The following is a description of a gene set: Cleft palate is a developmental defect of the palate resulting from a failure of fusion of the palatine processes and manifesting as a separation of the roof of the mouth (soft and hard palate). species: Homo sapiens Human Gene Set: HP_CLEFT_PALATE Cleft palate, and this is the list of marker genes: SLC35B2, SMARCB1, TRIP13, GDF3, RPS19, FANCF, ITGA8, DLK1, CPLX1, CHRNA1, DVL3, TMEM107, EIF4A3, HES7, PLCH1, RIPK4, GNAI3, NODAL, MECOM, MKKS, RAD51C, MAPRE2, PIGP, ORC6, GP1BB, PPP2R5D, EDN1, DISP1, NPHP1, MID1, GRHL3, FTO, CDH11 (NCBI Gene Id 1009), TRRAP (NCBI Gene Id 8295), ARHGAP29, POLR1D (RNA polymerase I and III subunit D), STIL, COL11A2, SUFU, PHF8, KCNN3 (potassium calcium-activated channel subfamily N member 3), MEGF10, FANCE, SOX3, RPS29, HDAC9, UBE2T, JUP, NDUFB11, ARNT2, FLRT3, SLC18A3, DPYSL5, SMOC1 (SPARC related modular calcium binding 1), PNKP (NCBI Gene Id 11284), PGM1, TBX2, SCN2A, SLC35D1, SON, COL9A3, POMK, BRAF, NXN, ZMPSTE24, KAT6B, GPC3, SLC25A19, SLC10A7, EARS2, MEOX1, RPS23, HAAO, FOXP2, SCN1B, COBLL1, POMT2, COL2A1, SEPTIN9, CHD7, MAP3K7, NAE1, AR, POMGNT2, HSPG2, TMEM67, STAT3, WDR26, HS6ST1, NELFA, EIF5A, GNRHR, STAG2, ESCO2, TRAPPC2, DLL3, INPP5E, DEAF1, FOXC2, COLEC11, FOXH1, CTBP1, MAP2K2, SMAD3, HS2ST1 (NCBI Gene Id 9653), TXNDC15, CEP152, MAPK1, ESS2, MESP2, TUBB, NSUN2, DLL1, RPL15, RBM10, ORC4, RIC1, ATR, TOPORS, DGCR8, GATA3, TCOF1, EDEM3, SCARF2, PITX1, TBR1, EIF2S3, ZPR1, ARCN1, SIX1, FKRP, GATA1, RPS17, GNB2, PAX3, PLAG1, CHRNG, SMCHD1, NDNF, MSX2, CHN1, TXNL4A, SOX10 (NCBI Gene Id 8223), C2CD3, B3GALT6, MSX1, NOTCH3, SUMO1, PDZD8, TWIST1, VAX1, SELENOI, RPL26, PGAP3, BMP4, SNRPN, PROP1, HIRA, MAMLD1, IGF2, DLG1, SCNM1, TMEM216, SOX9, TAPT1, COLEC10, TBX15, KIAA0753, SLX4, ACBD6, PTDSS1, MCTP2, NUP107, NFIX, JARID2, FKBP14, ATP6V1B2, RPL27, PTCH1, PIGN, POGZ, MASP1, KISS1, NFASC, PROK2, ATN1, PEX7, ANOS1, TCTN2, IGBP1, FANCB, PGAP2, CASK, SMS, BMPER, LMBRD1, RPGRIP1L, CHSY1, MT-CYB, FOXF1, H4C5, NSD2, LIG4, CEP120, MED25, TBX6, GNPAT, ERCC4, GLI3, CREBBP, EPG5, DEF6, AHDC1, BRIP1, RPS24, RPL5, CRPPA, WNT9B, CDT1, INTS1, MUSK, DYRK1A, MEIS2, FGF20, SCUBE3, GDF6, MAD2L2, CRKL, WBP11, FOXA2, TAF4, FAM50A, KLHL41, CARS1, SIX3, FANCL, RPL8, USP9X, GAD1, INPPL1, SPECC1L, FLNA, MYL11, RFWD3, OFD1, CCN2, CEP57, TFAP2A, TP63 (NCBI Gene Id 8860), POMT1, SHH, DONSON, B9D2, HNRNPK (NCBI Gene Id 3190), HCCS, PLXND1, SMC1A, MEG3, YAP1, PDGFRA, MYMK, GNAO1, ARID1A, WBP4, ECEL1, TCTN1, TGFBR1, GAS1, FAM149B1, HEATR3, RREB1, PDE6D, RPS10, SPRY4, LMX1B, SLC26A2 (solute carrier family 26 member 2), DLG5, TFE3, WNT3, BCOR (BCL6 corepressor), LRRC32, WASHC5, ZNF469, NIPBL, NR4A2, JMJD1C, B3GALNT2, PRR12, TGFB3, RXYLT1, FANCI, KDM6A, WNT5A, PUF60, MAFB, RNU4ATAC, RECQL4, NEDD4L, TMEM237, SEMA3A, DLX4, RAD51 (NCBI Gene Id 5888), RAB34, PRKAR1B, RAD21, POLR3A, KCNJ2, AHI1, EFTUD2, GLI2, DVL1, BUB1, SEMA3E, SEC23A, KIF15, UFD1, MED12, TACR3, HMGA2, GREB1L, SPINT2 (NCBI Gene Id 10653), FGD1, DLX5, TGFBR2, KIF21A, SIAH1, FBXO11, FKTN, RAPSN, DSP, RPS26, DGCR2, GMNN, ASCC3, PRDM5, DHCR7, SMO, SALL4, RUNX2, CRELD1, KIF7, ARHGEF38, BUB3, GPC4, ANKRD11, KAT5, UBB, BUB1B, TUBA1A, BRD4, ARVCF, ZEB2, PALB2, GMPPB, CHST3, RNU12, FGF17, LZTR1, GNB1 (NCBI Gene Id 87729), CC2D2A, SMARCD1, SLC25A22, CCDC32, CSPP1, HESX1, AMMECR1, PORCN, DUSP6, RPL35A, SLC2A10, RPL31 (ribosomal protein L31), NUAK2, LHX4, FEZF1, ADA2, RPS20, POLR1A, LETM1, PTPN11, RSPO2, CHRND, FRAS1, SF3B2, MYH3, RPL9, MAGEL2, POMGNT1, DMXL2, CDKL5, FGFR1, ALX3, FLVCR2, TCTN3, ATP6V1E1, ALX1, IPO8, CHST14 (NCBI Gene Id 89881), CCDC141, CYP26C1, FOXE1 (forkhead box E1), RPS27, TAC3, CENPF, ARID1B, FGFR2, OTX2, NEK1, RARB, ZIC2, WNT7A, PIGV, RPL35, CRIPTO, RET, RPS7, KISS1R, TAF6, FOXI3, ALX4, CDC6, DPH1, WDR11, PIGQ, ZFX, GRM7, RPS28, CDON, NONO, DOK7, NUP88, SMC3, MAF, FANCG, RPL18, PEX2, ORC1, CDC45, RIPPLY2, SNRPB, DSE, PEX5, B3GAT3, ARHGAP31, HYAL1, COL4A1, LARS2, WNT4, TMCO1, RB1, RBM8A, EYA1, NBN, FAM20C, ACTB, BPNT2 (NCBI Gene Id 54928), TMEM231, POLR1C, FANCD2, CHUK, GNRH1, SETD5, FANCC, B9D1, BRCA2, KRAS, PSAT1, B4GAT1, CDH1, LARGE1, KATNIP, KIAA0586, SMARCA4, GRIN1, SLC32A1, COL11A1, KMT2D (NCBI Gene Id 8085), GDF11, SH2B1, CTNND1, KDF1, HDAC8 (NCBI Gene Id 7492), NOTCH2, INTU, PIEZO2, FGF9, TBX4, STAC3, COL9A1, WDR35, PQBP1, FGFR3, COMT, TBX1, ACTG2, POLR1B, ZC4H2 (NCBI Gene Id 7493), SF3B4, CEP41, REV3L, EBP, POLR2A, RPL11, NEUROD2, NECTIN1, KANSL1, PLCB4, MYMX, LEMD3, EBF3 (EBF transcription factor 3), HOXD13, ACBD5, ARX (NCBI Gene Id 619216), POU1F1, STAMBP, XRCC2, FGF8, SOX2, IRF6, SIX5, MKS1, LBR, NEB, GABRA3, ZSWIM6, SATB2, VPS35L, LMNA, SIK1, KCNK9, DCC, SMAD4, FZD2, RAI1, TELO2, CUL3, GFRA1, BCR, EFNB1, SET, CDKN1C, TGIF1 (TGFB induced factor homeobox 1), PIGO, DHCR24, TBC1D24, KCNA1, DDX59, FANCM, BICRA, EP300, HOXA2, MYOD1, TSR2, NHLH2, AMER1, KCNH1, B4GALT7, COX7B, DAG1, SOX6, XYLT1, RPS15A, DYNC2H1, CTCF, PIGG, TRPV4, MAP2K1, DHODH, SEC24C (NCBI Gene Id 9632), DDX3X, DGCR6 (DiGeorge syndrome critical region gene 6), PRRX1, FLII, COG1, ERCC5, IL17RD, ANKRD17, PIGL, MBTPS2, CILK1, RPGRIP1, PHGDH, CEP290, CCDC22, PPP3CA, SPOP, CPLANE1, FILIP1, ARID2, ASXL1, DPH2 (diphthamide biosynthesis 2), NSMF, FANCA, GJA1, TRIM8, CD96, LFNG, EDNRA, TBX5 (NCBI Gene Id 6910), TBX22, HYLS1, PROKR2, TGDS, GJB2, FGFRL1, COL9A2, KIFBP, KAT6A (NCBI Gene Id 7994), G6PC3, BRCA1, RTL1, IQSEC2 (IQ motif and Sec7 domain ArfGEF 2), FLNB, B3GLCT